The following is a description of a gene set: studied in species Mus musculus Mouse Gene Set: GOBP_PROGRAMMED_CELL_DEATH_INVOLVED_IN_CELL_DEVELOPMENT The activation of endogenous cellular processes that result in the death of a cell as part of its development., and this is the list of marker genes: Mael, Il1a, Prkdc, Kitl, Unc5c, Ybx3 (NCBI Gene Id 56449), Ddb1, Casp2, Cntf, Syce3, Topaz1, Bhlhe23, Bcl2, Casp6, Fasl, Bdnf, Fgf2, Slc4a7, Ube2b, Bcl2l1, Tmem215, Kit, Dnase1l3, Lrriq1, Rhox5, Insl6, Tex11, Sod1, Casp4, Il1b, Sycp2, Bax, Ntrk1